The following is a description of a gene set: Mouse Gene Set: GOBP_OXIDATIVE_DEMETHYLATION species: Mus musculus The process of removing one or more methyl groups from a molecule, involving the oxidation (i.e. electron loss) of one or more atoms in the substrate., and this is the list of marker genes: Cyp2d22, Cyp1a2, Cyp3a13, Cyp3a41a, Cyp3a44, Cyp3a41b, Jmjd6, Alkbh1, Cyp3a57, Cyp3a16, Cyp3a59, Cyp3a25, Cyp3a11